The following is a description of a gene set: Mouse Gene Set: GOBP_TISSUE_HOMEOSTASIS A homeostatic process involved in the maintenance of an internal steady state within a defined tissue of an organism, including control of cellular proliferation and death and control of metabolic function. studied in species Mus musculus, and this is the list of marker genes: Rp1l1, Srf (serum response factor), Bbs12, Prlh, Tff3, Cxadr, Bap1, Mks1, Spp1, Lrp6, Car2, Fosl2, Abcb1a, Clrn1, Clcn3, Nphp4, Aipl1, Nanos1, Ubash3b (ubiquitin associated and SH3 domain containing, B), Dcstamp (NCBI Gene Id 75766), Rab7, Atf1, Bbs10, Mbp, Tjp3, Iqcb1, Cd34, Adgrv1, Nox4, Coro1a, Pbld2, Tcirg1, Ccr2, Ankrd11, Slc39a8, Abca4, Nfix (NCBI Gene Id 18032), Ush1c, Nphp3, Ada, Tnfsf11, Siglec15, Gata1, Klhl10, Pbld1, Tnfrsf11b, Akr1b1, Cib2, Abcc1, Atp1b2, Il17a, Fcgr4, Inava, Ank, Wnk3, Vsig1, Brinp1, Bbs2, Cbl, Acaca, Tulp1, Inpp5d, Adora1, Comp, S1pr1, Gnasas1, Crb2, Wwtr1, Ldb2, Prdx5, Add1, Abcc8, Perp, Map1a, Mkks, Nxnl1, Chmp4b, Ptpn11, Lipa, Nod2, Fshr, Bbln, Pth1r, Flt3l, Zfp830, Gcnt2, Ctss, Ltbp3, Mc4r, Yap1, Csk, Idua, Enpp1, Bsg, Whrn, Gigyf2, Bdkrb2, Vegfa, Smo, Ihh, Col2a1, Muc5ac, P2rx7, Bax, Cytl1, Rpa1, Snx10, Stk39, Def8, Tfrc (NCBI Gene Id 76361), Egfr, Hnf1a, Nt5e, Pdgfrb, Exoc5, Ildr1, Cdh3, Mak, Lrrk1, Sh3gl2, Col3a1, Tnfrsf11a, Dram2, Bbs1, Hoxa13, Piwil4, Mfsd2a (NCBI Gene Id 76574), Syk, Ncdn, Cngb1, Rac1, Spata7, Elp6, Minar2, Akt3, Cyp19a1, Ahsg, Vstm4, Muc4, Crb1, Csf1r, Mip, Epsti1 (epithelial stromal interaction 1), Mir140, Slc28a2, Pcdh15, Fh1, Src, Fshb, Il6, Dlg1, Rbp4, Alpl (NCBI Gene Id 11647), Bbs4, Ppargc1b, Calcr, Trp53inp2, Slc28a2b, Dlk1 (NCBI Gene Id 13386), Trf, Vps13b, Prkca (protein kinase C, alpha), Mtf1, Kcnj1, Rac3, Tlr4, Cln8, Rp1, Bcl2, Abcb1b, Ercc6, Strap, Rab3d, Gnas, Scx, Htr4, Fsip1, Ocln, Itgb1, Pkp3, Adam8, Gata2, Notch1, Slc22a21, Tmem64, Tmem119, Itgav, Aldh1a1, Ptger4, Errfi1, Apbb2, Nos3, Tub (TUB bipartite transcription factor), Iapp, Ceacam1, Pth, Ush2a, Ush1g, Rufy4, Hamp, Cd38, Ccdc66, Lsr, Cartpt, Cldn18, Tns3, Vps54, Lca5, Slc12a2, Gpr55, Slc2a1, Sod1, Wdr36, Sox9, Csf1, Usp45, Abcc6, Cep290 (centrosomal protein 290), Tff1 (NCBI Gene Id 21784), Ift80, Cd7, Adrb2, Creb1, Tpp1, Cdhr1, Ptgs2, Prom1, Tuba1a, Il10ra, Slc4a2, Crocc, Sash3, Itgb3 (NCBI Gene Id 268495), Rho, Slc1a1, Xiap, Ctnnb1, Cracd, Rpe65, Prdm14, Ndp, Tjp1, Slc22a5, Zeb2, Il20ra, Angpt1, Nfkbiz, Arap1, Naglu, Poc1b, Esrrb, Prickle1, Pde6a, Tspan12, Ascl3, Col9a1, Oscar, Il20rb, Ptk2b, Nf1, Gpr137, Norad, Col11a2, Trim32 (tripartite motif-containing 32), Rac2, Tff2, Nxnl2 (nucleoredoxin-like 2, NCBI Gene Id 75124), Slc28a3, Scrib, Col14a1, Kmt2a, Ildr2, Tlr9, Ext1, Acp5, Trgc1, Ctsk, Rb1, Ptgs1, F2r, Gpr137b, Muc13, Epg5, Ccdc154, Plekhm1, Gnat2, Cd2ap, Tjp2, Cdh23, Kras, Vhl (NCBI Gene Id 22346), Nfib, Pdk4 (pyruvate dehydrogenase kinase, isoenzyme 4), Flt3, Ifnb1, Stk11, Neurod1, Cldn5, Ccn2, Adora2a, Muc2, Pantr2, Abcg2, Traf6, Prrc1, Tex15, Ldb1, Foxc1, Il7